The following is a description of a gene set: Mouse Gene Set: GOBP_PROTEIN_BRANCHED_POLYUBIQUITINATION A protein ubiquitination process in which ubiquitin monomers are attached to a protein, and then ubiquitin polymers are formed by linkages between lysine residues at various positions of the ubiquitin monomers, forming branched linkages, such as K11/K48- or K11/K63-linked chains. species: Mus musculus, and this is the list of marker genes: Ubr5, Anapc2, Anapc16, Anapc13, Cdc27, Anapc15, Cdc23, Anapc10, Anapc5 (NCBI Gene Id 67965), Anapc11, Cdc26, Anapc4 (anaphase promoting complex subunit 4), Anapc1, Traf6, Cdc16, Ubr4, Huwe1, Itch, Anapc7